Given this list of marker genes Urb1, Ddx39b, Prmt1, Stat3, Mrto4, Zpr1, Piwil1, Snrpf, Pum2 (pumilio RNA-binding family member 2), Cdc5lrt6 (cell division cycle 5 like, retrotransposed 6), Ddx42 (DEAD box helicase 42), Hnrnph2, Snrpa, Nup98, Upf3b, Tsnax, Znhit6, Aqr, Las1l, Ints11, U2surp (U2 snRNP-associated SURP domain containing), Supv3l1, Dhx9, Ctu1, Kat2a, Isg20l2, Rrp36, Cdc5lrt7, Cwc25, Ildr2, Rbm10, Son, Psip1, Imp4, Dbr1, Hmx2, Snw1, Adat1, Elp1, Prorp, Ints1, Srsf9, Rps25, Gemin4, Slc38a2, Apobec1, Usp36, Tut4, Rexo5 (RNA exonuclease 5), Gtpbp3, Rpl7, Sf3b1, Lin28b, Prkra, Taf12, Pelp1, Cdc5lrt5, Wdhd1, Pus10, Jmjd6 (jumonji domain containing 6), Prpf40a, Fars2, Utp18, Pih1d2, Rrp7a, Ago1, Sfswap, Trmt13, Usp39, Ddx17, Arl6ip4, Hnrnpa2b1 (heterogeneous nuclear ribonucleoprotein A2/B1), Bud31, Trmt61a, Kat8 (K(lysine) acetyltransferase 8), Pcif1, Scnm1, Utp23, Fbxo24, Rpl11, Tprkb, Tex15, Mfap1b, Rpl5 (NCBI Gene Id 19983), Rnpc3, Ak6, Rpp14, Wdr83, Rbm3, Rpp30, Rbm14, Trdmt1, Xrn1, Habp4, Krr1, Slu7 (SLU7 splicing factor homolog (S. cerevisiae)), Rps19, Nop2, Pum1, Scaf4, Ebna1bp2, Sugp1, Mak16, Nudt16, Mrm3, Pusl1 (pseudouridylate synthase-like 1), Smu1, Lin28a, Ddx27, Fto, Prpf4, Celf3, Elp3, Lsm1, Mterf4, Mettl3, Pde12, Slc39a5, Srrm2, Mettl5, Isg20, Pqbp1, Adat2, Trp53, Malat1, Rpusd2, Pcbp4, Utp14a, Rrp1, Rps15, Elp4, Wdr4, Dimt1, Nhp2, Pabpc1, Trmu, Snrnp25, Isy1, Sf3a1, Hsf1, Celf2, Prpf39, Ppwd1, Dhx40, Cwc22rt4, Adar, Ints6l, Mtpap (NCBI Gene Id 67440), Wdr6, Bud23, Ints8, Thrap3, Rps24, Smndc1, Tdrd12, Mtfmt, Cpsf2, Tmt1a2, Rnf113a2, Clk4, Mbnl2, Pus1, Nop10, Trmt10c, Ints4, Tsr3, Ppih, Cenatac, Gar1, Tsn, Srpk2, Dus2, Magohb, Slbp, Celf6, Rps28, U2af1, Papolb, Ddx20, Eri1, Taf5l, Gpkow, Prmt9 (NCBI Gene Id 234462), Cwf19l1, Hnrnpl (NCBI Gene Id 97377), Yju2, Ddx49, Ddx51, Rprd1b, Zfp473, Tut7, Osgepl1 (NCBI Gene Id 98202), Ssu72, Dhx38, Chd8, Tarbp1, Ccnb1, Trmt44 (tRNA methyltransferase 44), Syncrip, Cwc22rt2, Trnt1, Rsrp1, Ddx46, Kin, Akt1, Cdkal1, Ints14, Hnrnpf, Larp7-ps, Sfpq, Gemin7, Qng1, Brix1, Ddx18, Thumpd2, Ddx47, Snrpg, Utp11 (UTP11 small subunit processome component), Pnpt1 (NCBI Gene Id 71701), Rbm6, Thoc1 (THO complex 1), Tmtc1, Sgf29, Zbtb8os, Nup155, Ssb, Arglu1, Prpf19, Aar2, Trmt1, Hspa8, Rps26, Zfp638, Armc7, Ern1, Ints3, Trmt11, Gemin6, Rbpms2, Ess2, Akap8l, Zrsr2, Fcf1, Pdcd11, Celf4, Bud13, Zc3h7b, Osgep, Npm1, Hdac7 (NCBI Gene Id 56233), Tyw3, Tdrkh, Ddx4, Tia1, Rbpms, Exosc4, Ppil1, Lmntd2, Kat2b, Sugp2, Pop1, Rprd1a, Wdr36, Cirbp, Nat10, Ago2, Utp20, Tssc4, Zc3h13, Ddx41, Ercc2, Ints10 (integrator complex subunit 10), Adarb1, Zfp36l1, Ptcd2, Rbmxl2, Cdk5rap1, Ttf2, Cpsf4, Rps8, Rtca, Umod, Akr1c6, Snrpd1, Rbm38, Tyw1, Rnu12, Angel2, Rps6, Ngdn, Ppil3, Cstf2t, Sirt7, Rpp25l, Zranb2, Plcb1, Wt1, Scaf8, Cript (cysteine-rich PDZ-binding protein), Clasrp, Ahnak, Luc7l3 (LUC7-like 3 (S. cerevisiae)), Pnldc1, Ddx10, Ahcyl1, Lsm2, Ilf3, Rbmyf9, Zcchc4, Papola, Ftsj1 (FtsJ RNA 2'-O-methyltransferase 1), Rps27, Rbm44, Rnu2-10, Snrpn, Hnrnpul1, Mettl14, Atxn7l3, Rpf2, Dhx37, Parn, Sltm, Tgs1, Nono, Eif6, Mbnl3, Rpp25, Wdr18, C1d, Ddx21, Rbm47, Rbm39, Bms1, Mblac1, Ankrd16, Esrp2, Clp1, Akt2, Ppil2, Prkaca, Tarbp2, Ythdf2, Cbll1, Nol10, Ddx3x, Usp22, Rest, Wdr46 (WD repeat domain 46), Cdkn2a, Ftsj3, Snrpe, Rbmyf1, Rbm22, Rpp40, Rnu11, Supt6, Rnps1, Rbm41, Suv39h1, Slirp, Rexo1, Taf9, Exosc2, Dalrd3, Rngtt, Zfp326, Setx, Srpk1, Pwp2, Npm3, Mettl16, Lage3, Exosc8, Rrp15, Nol8, Fus, Crnkl1, Cwf19l2, Prkdc, Rpl35, Taf6l, Ppp4r2, Esf1, Ccnl1, Khdrbs1, Raly, Lcmt2, Gcfc2, Prpf3 (pre-mRNA processing factor 3), Aicda, U2af1l4, Ddx52, Cdk12, Snrpc, Zcchc8, Zc3h10, M1ap, Rbm11, Rps7, Wdr43, Gtf2h5, Cdc73, Snrnp70 (small nuclear ribonucleoprotein 70 (U1)), Alyref, Elac2, Rbm4b, Hnrnpll, Clk1, Ccar2, Utp25, Sf3b3, Prdx6, Elavl4, Zfp830, Slx9, Rbm34, Rbmy, Trit1, Cdk9, Lsm11, Tyw5, ENSMUSG00000126352, Fam50a, Tsen15, Ramac, Srsf6, Nvl, Pnn, Exosc10, Safb2, Tfb1m, Ddx54, Fip1l1, Grsf1, Exosc5, Trmt10a, Dazap1, Eif4a3, Plrg1, C1qbp, Snip1, Ncbp3, Ncbp2, Srsf8, Rbbp6, Tdrd1, Dyrk1a, Pcbp1, Rpl7a (NCBI Gene Id 30787), Cdc5lrt9, Mtrex, Prpf18, Sf1, Rbfox1, Cwc22rt1 (CWC22 spliceosome-associated protein, retrotransposed 1), Trpt1, Wdr74, Rbmxl1, Prmt7, Trmt2a, Cpeb1, Smn1, Tent4b, Akap17b, Rpusd4, Ncl, Arvcf, Fastkd3, Ptbp2, Rpl14, Exosc3, Sars1, Yrdc, Gpatch8, Rpf1, Alkbh5, Magoh, Mov10l1, Utp14b, Tent4a, Bop1, Sap18b, Snrpd3, Rcl1, Qtrt1, Chd7, Srsf12, Srek1 (NCBI Gene Id 404583), Pes1, Khdrbs3, Rbm42, Sde2, Celf5, Sf3a2, Aff2, Rtraf, Snrnp40, Snu13, Tbl3, Hnrnpa1, Rrp8, Tra2a, B3gntl1, Zfp64, Tgfb1, Ildr1, Riok2 (RIO kinase 2), Rpl7l1, Polr2a, Thoc5, Abt1, Thumpd3, Pabpn1, Rpl27 (ribosomal protein L27), Sf3a3, Tdrd9, Cwc22rt6, Nsa2, Rps14, Arb2a, Rbm8a, Hnrnpc, Hnrnpm, Fastk, Celf1, Thoc2, Cdc5l, Eny2, Trim71, Rbmx2, Ddx39a, Mettl1, Ago4, Pop7, Mir361, Iws1, Dph3, Taf10, Exosc1, Cherp, Utp6, Trmt1l, Cdc5lrt1, Gpat2, Kti12, Cdc5lrt4, Brdt, Rnu7, Wdr75, Rbmx, Cdc5lrt10, Snrpb, Lsm10, Rbm12b1, Trmo, Prpf8, Trrap (transformation/transcription domain-associated protein), Lsm3, Mrpl44, Rpl26, Pop4, Thoc7, Ptcd1, Rbm48, Hnrnpk, Utp4, Rbm5, Drosha, Lsm8, Sf3b6, Aen, Ctu2, Cwc22rt5 (CWC22 spliceosome-associated protein, retrotransposed 5), Srrm4, Bcas2, Cdk11b, Frg1, Ddx5, Prpf38a, Leo1, Tent2, Rbm20, Prkrip1, Dicer1, Fastkd2, Tmt1a, Apobec2 (NCBI Gene Id 11811), Ncbp1, Dhx36 (NCBI Gene Id 99809), Trmt2b, Alkbh1, Ppan, Adad2, Rnmt, Ybey, Thada, Fra10ac1, Tsen34, Ints5, Cactin, Qki, Sf3b5, Mfap1a, Rpusd3, Ints2, Upf1 (UPF1 RNA helicase and ATPase), Bmp4, Tdrd7, Cpsf6, Pan3, Dis3, Luc7l, Mphosph6, Cstf3, Il6, Prpf38b, Prpf40b, Usp4, Wdr55, Rbfox3, Snrpa1, Fastkd1, Strap, Cwc22, Cir1, Apobec4, Rrp1b, Qtrt2, Snrnp35, Nsun2, Ccnl2, Syf2, Dcps, Dhx8, Alkbh8 (alkB homolog 8, tRNA methyltransferase), Rps17, Gemin6-ps, Nudt21, Ddx1, Srsf2, Exosc9, Scaf1, Tada3, Srsf3, Paf1, Aars1, Luc7l2, Trmt5, Riok3, Srrt, Rrp9 (NCBI Gene Id 27966), Thumpd1, Rprd2, Prpf4b, Tut1, Zcrb1, Fastkd5, Ptbp3, Lsm7, Dis3l, Nsun6, Srsf5, Trub1, Sart3 (NCBI Gene Id 53890), Ripk1, Mto1, Tdrd6, Tardbp, Rps27rt, Supt7l, Srsf1, U2af2, Dus1l, Usb1, Ubl5, Hnrnpul2, Tert, Trmt10b, Snrpd2, Casc3, Hnrnph3, Wbp11, Lgals3, Sbds, Rpp38, Rbm4, Ints9, Adarb2 (NCBI Gene Id 94191), Larp7, Pih1d1, Txnl4a, Mrm2, Nsrp1, Ubl5b, Virma, Heatr1, Gtsf1, Zc3h14, Taf15, Srsf4, Mecp2 (methyl CpG binding protein 2), Nob1, Snrnp27, Ppie, Ecd, Riok1, Rps16, Zmat5, Sf3b2 (splicing factor 3b, subunit 2), Fbll1, Trmt112, Rbm15, Pcf11, Ddx23, Pa2g4, Ints6, Eif4a3l1, Upf3a, Ddx56, Lsm5, Rbm24, Pdcd7, Ahnak2, Rbmyf6, Trmt6, Pus7, Wdr33, Piwil2, Cstf2, Obi1, Pus3, Rexo4, Thg1l, Htatsf1, Mettl8, Scaf11, Wtap, Ppp1r8, Sepsecs, Dtwd2 (DTW domain containing 2), Cdc40, Rpusd1, Mphosph10, Rbm7, Ints15, Safb, Srfbp1, Gon7, Cwc22rt3 (CWC22 spliceosome-associated protein, retrotransposed 3), Fbl, Phrf1, Imp3, Rps6-ps4, Mbnl1, Bysl, Rsrc1, Exosc6, Txnl4b, Hnrnph1, Rpl35a, Rbm15b (NCBI Gene Id 76348), Tfb2m, Srrm1, Emg1, Srsf10, Dtwd1, Hnrnpu, Srpk3, Nol7, Tsen2, Fmr1 (NCBI Gene Id 207836), Dkc1, Ybx1, Hsd17b10, Nova2, Rps13, Spout1, Wdr3, Nol6, Rbm8a2, Thoc3 (NCBI Gene Id 73666), Thoc6, Coil, Pik3r1, Phf5a, BC005624, Ptbp1, Utp3, Gm7324, Elp6, Pin4, Zc3h7a, Naf1, Wdr77, Rbm12, Trmt12, Acin1, Mocs3, Tada1, Kri1, Csdc2, Elp5, Snrnp48, Snrpert, Lyar, Rbm12b2, Znhit3, Nsun5, Esrp1, Mettl18, Trub2, Mettl2, Cnot6l, Zc3h3, Trp53rkb, Cmtr1, Dus4l, Nol9, Pld6, Tra2b, Tbrg4, Fdxacb1, Bcdin3d, Prx, Rbm25, Lsm4, Dhx16 (NCBI Gene Id 69192), Supt20, Ik, Cdc5lrt8, Clns1a, Prpf6, Zmat2, Nrde2, Clk3, Rps21, Rp9, Cpsf1, Gemin8, A1cf, Prpf31, Myg1, Tfip11, Piwil4, Ctnnbl1, Cpsf7, Rbm28, Gemin2, Dcaf13, Sap18 (Sin3-associated polypeptide 18), Ythdc1, Mettl15, Rtcb, Nop14, Ern2, Gemin5, Tsr1, Eif4a3l2, Rrs1, Cd2bp2, Henmt1, Elp2, Ints12, Ago3, Wbp4, Sf3b4, Xab2, Cwc22rt7 (CWC22 spliceosome-associated protein, retrotransposed 7), Clk2, Hnf1a, Trmt9b, Larp6, Ivns1abp, Rbmyf3, Cpsf3 (NCBI Gene Id 54451), Exosc7, Rbfa, Puf60, Fkbp6, Dhx15, Pak1ip1, Mettl6, Tcerg1, Prmt5, Gpatch1, Khsrp, Pabpc2, Gtdc1, Xrn2, Prdx6b, Mettl4, Hnrnpa3, Yju2b, Tmt1a3, Zmpste24, Nol3, Eftud2, Alyref2, Sart1, Nop9, Papolg, Exd1, Dnttip2, Paxbp1, Mrm1, Dgcr8, Adad1, Ints7, Pop5, Nsun3, Nop53, Urm1, Utp15, Rbm17, Tsen54 (tRNA splicing endonuclease subunit 54), Tmbim6, Pan2, Adat3, Srsf7, Usp49, Mael, Khdc4, Mepce, Snrpb2, Cstf1, Adam3, Elac1, Pus7l (NCBI Gene Id 78895), Rnasel, Nsun4, Nol11, Khdrbs2, Atxn7, Rbfox2, Wdr12, Snrnp200, Pwp1, Rpp21, Dnajc17, Myod1, Dus3l, Cdk13, Cmtr2, Rnf113a1, Sympk, Tsr2 (TSR2 20S rRNA accumulation), Cwc15, Eif1, Toe1, Zbtb7a, Lsm6 (LSM6 homolog, U6 small nuclear RNA and mRNA degradation associated), Gtpbp4, Srek1ip1, Nova1, here is a description of the gene set: Any process involved in the conversion of one or more primary RNA transcripts into one or more mature RNA molecules. studied in species Mus musculus Mouse Gene Set: GOBP_RNA_PROCESSING